The following is a description of a gene set: species: Homo sapiens Human Gene Set: GOBP_MITOTIC_CELL_CYCLE_PHASE_TRANSITION The cell cycle process by which a cell commits to entering the next mitotic cell cycle phase., and this is the list of marker genes: TEX14, KLHL22, TRIM39, CUL4B, MIR495, BABAM1, SMARCA2, SPAST, RAD21, CCND2, TREX1, MTBP, MYB, DPF2, TFDP1, SPDYA, MTA3, RCC1, DNM2, TAOK2, MYO16, KMT2E (lysine methyltransferase 2E (inactive)), VPS4A, PPP2R2D, NAE1, AKT1, CLSPN, MIR519D, CHFR, CDK4, MRNIP, ANXA1, RPA2, SASS6, FBXO5, FZR1, DDR2, GSPT1, MIR515-1 (microRNA 515-1), IK, ANAPC1, AMBRA1, RAD50, RBL1, TAOK1, FOXN3, PHF10, UBD, AURKA, XRCC3, CDCA5 (cell division cycle associated 5), CDC6, PPP2CA, TRIP13, MBTPS1, USP26 (NCBI Gene Id 83844), CDC20, TMOD3, PLCB1, CDK14, MAD2L2, NEUROG1, CDK5RAP3, CHMP4B, ZWILCH, DTL, CDK7, ANAPC7, CTDSP1, RHOU, BARD1, CCNY, SYF2, PIAS1, WAC, MIR195, PSME2, USP29, SPDL1, CALM3, ZNF655, CPSF3, APPL2, WNT10B, CACNB4, BCL7A, SMC5, CKS2, ETAA1, MELK, ESPL1, CDKN2B, MUC1, MIR15B, NFIB, MIR221, HUS1, CCNB1 (cyclin B1), MIR520A, SMARCD1, RPS6KB1, RPS27L, DLGAP5, KLF4, ZWINT, PKD2, CCNE2, CCNG1, MIR29C, PTENP1-AS, AVEN, DLG1, TPR, CDK10, DPF1, TICRR, CCNI2, RAD51C, DYNC1LI1, DPF3, MIR372, MEPCE, ANAPC4, BCL7B, BTN2A2, STK35, ADAM17, ANAPC11, TERT, MIR133B, RFPL1, USH1C, GTPBP4, KLF11, GPR132, PRMT2, ECD, MAD2L1, MYC, CHMP4C, HSPA2, KCNA5, CDC14C, HECW2, GFI1B, GPNMB (NCBI Gene Id 10457), MIR222, MRE11, BID, RRM2, ACTL6B, CHMP2A, RBBP8, PRKDC, RPL24, ZFYVE19, ADAMTS1, CUL3, POLE, NOP53 (NOP53 ribosome biogenesis factor), LATS1, KIF14, CHMP7, RAD51B, CCNI, APC, PDIK1L, CDC23, CLASP2, CALM2, BRD4, CDKN1A, CCDC57, NFIA, ENSA, PSME1, BRCA1, ID2, FBXL7, ITGB1, BCAT1, MIR520H, EPS8, USP22, DONSON, DBX2, MDM2, CENPJ, E2F3, CDC7 (cell division cycle 7), SKA3, CCNH, AURKB, KNTC1, DGKZ, MNAT1 (NCBI Gene Id 4331), UBE2E2, ERCC3 (NCBI Gene Id 2071), TP53, RRM2B, DBF4B, CCNE1, USP37, ID4, DUSP1, BABAM2, ZW10, CCNG2, ZNF324, CCNF, TMEM14B, KLHL18, MIR16-1, RFWD3, CTDSP2, ACTB, NES, TACC3, KHDRBS1, FAM107A, HINFP, LSM11, SMARCB1, NDC80, MIIP, ARID1B, JADE1, INCENP, ZNF830, PKD1, ZNF207, TFAP4, CDC14B, PKIA, PSME3, MIR30C2, CCNB3, RINT1, ORC1, VPS4B, UBE2S, USP44, NSMCE2, MIR214, FBXO7, DACT1, MAD1L1, ANLN, PIM2, ACTL6A, TPD52L1, UIMC1, AIF1, IER3, TOPBP1, TFDP3, EGFR, STIL, RCC2, RPTOR, FBXO31, CUL2, MIR362, BRSK2, MASTL, MAP3K20, IQGAP3, SPC25 (SPC25 component of NDC80 kinetochore complex), CENPE, PPP3CA, MBTPS2, HEXIM2, RDX, HASPIN, TM4SF5, SMARCD3, ACVR1B, CDKN3, CDC34, CDC16, CDK6, RAD17 (NCBI Gene Id 5884), CRLF3, CCNA2, MIR133A1, PSMG2, SMARCE1 (SWI/SNF related, matrix associated, actin dependent regulator of chromatin, subfamily e, member 1), CDK2, CDC27, TAF2, SIRT2, MIR15A, CHEK2, ARID1A, INO80, CDC25C, PTPN6, KANK2, BRSK1, EZH2, SMARCC1, CCNO, CCNP, SIN3A, PRP4K (NCBI Gene Id 8899), FHL1, CENPF, ARID2, CUL4A, FGF10, RBL2, TTK, KDM8, NEK11, MBLAC1, BCL7C, CCL2 (C-C motif chemokine ligand 2), TRIAP1, NUF2, CHEK1, EIF4EBP1, ZC3H12D, PLK3, ATAD5, CDK3, RRM1, FBXL15, PTEN, MIR137, ZFP36L2, BUB1B, ERCC2, BIRC5, SMARCD2, NEK6, CUL5, MIR26A1, CDC25B, ABRAXAS1, CCNB2 (NCBI Gene Id 9133), CTDSPL, MIR193A, CYP1A1, PPM1D, SKP2, NABP2, NPM2, DBF4, TAF10, MIR19B1, CUL1 (cullin 1), BRCC3, UBE2A (ubiquitin conjugating enzyme E2 A), CCND1, CCNA1, CDC73, ANAPC15, FOXO4, PBX1 (PBX homeobox 1), UBE2C, ANAPC2, CDC25A, NBN, RGCC, RAB11A, TPRA1 (NCBI Gene Id 63108), DCUN1D3, PPP1R9B, LSM10, ACVR1, SDE2, ATR (NCBI Gene Id 57307), TGFB1, PLRG1, CCNJ, SKA1 (spindle and kinetochore associated complex subunit 1), RB1, PABIR1, CDKN2A, TCF3, PKMYT1, CDK5RAP2, CCND3 (NCBI Gene Id 896), CDK1, E2F1, STOX1, PINX1, PLK2, RNASEH2B, PHF8, CALM1, LATS2, BLM, SMARCA4, MIR892B, CLASP1, WEE1, MIR451A, MIR29B1 (microRNA 29b-1), ABCB1, PLK5, LCMT1, PLK1 (NCBI Gene Id 5347), PHOX2B, CDKN2C, PBRM1, MIR208A, RIOK2, CTC1, BCL2, ANKRD17, ZFP36L1, DDX3X, ANAPC5, GIGYF2, FOXM1, ARPP19, CDK2AP2, INHBA, XPC (XPC complex subunit, DNA damage recognition and repair factor), MAD2L1BP, BUB3, MIR29A, BRD7, APPL1, EIF4G1, INTS3, CACUL1, SPC24, CAMK2A, ATM, SENP2, CTDP1, CCNJL, INIP, KNL1, PRAP1, TAOK3, E2F7, EIF4E, CDKN2D, CDCA8, MARK3, TRIM71, BUB1, CDKN1B, PPME1, SLFN11, SMARCC2, DDB1, MIR638 (NCBI Gene Id 693223), CDKN1C, HUS1B, KCNH5, NABP1, CDC14A, GEN1, PPP6C